Given this list of marker genes CAPNS1, MPV17, DNAJC21, GTF2IRD1, RTN2, SVIL, GATB, TAMM41, SETX, NCF1, KRT5, UROS, G6PD, CIITA, STAT2, FOXP3, COL4A3, KIT, FKTN, WDR73, NPHS2, HEXB, TSHB, FOXI1, SLC40A1, SLC22A5, LAMA1, RRM2B, PIGA, SLC25A4, GYG1, CPOX, SERPINA6, NOS1 (NCBI Gene Id 4842, nitric oxide synthase 1), ARPC5, LIN28B, FRG1, PROP1, ALG12, MYOT, PHKG2, BSCL2, PDK3, AGPAT2, IRF5, PHKB, ACSL5, TNPO3, PLA2G6, MPI, SIL1, KY, ALG2, B4GALT1, PLVAP, LPL, IYD, ATP6V1A, LMNA, SGCD, DGKE, LDHA, DOK7, ISCU, COA7, HADH, TTN (NCBI Gene Id 7847), IFT56, STIM1, AP1B1, SLC7A7, PAX8, ARHGAP24, ADSS1, DPAGT1, MYMK (NCBI Gene Id 389827), RRM1, SKIC3, MGME1, CEL, GPR35, PIGN, PKLR, CCDC115, CNOT1, NUP107, MB, SYNJ1, TNNT2, TRAF3, TWNK, NLRP1, THPO, LYST, HMOX1, COL12A1, DHCR7, PYROXD1 (NCBI Gene Id 79912), MAP2K1, QRSL1, POPDC3, PITRM1 (NCBI Gene Id 22910), BCS1L, GNPTG, SMCHD1, TBCD, GNPTAB, ASAH1, CTNNB1, ZNFX1, USB1, HNRNPA2B1, ABHD5, ACTN4, ALG14, MYH14, C1QBP, IL6ST (interleukin 6 cytokine family signal transducer), FN1, HADHA, WDR4, STX1A, ABCG8, TMEM199, MEFV, POLG2, BAG5, GGPS1, RNF31, TBCK, DMD, BICD2, SLC30A9, DSG2, TMEM270, COL25A1, CASR (calcium sensing receptor), INS (NCBI Gene Id 3630), NGLY1, SLC34A1, ADRA2A, QRICH1, EMP2, FOS, CLIP2, FAS, HLA-DPB1, EPG5, MYPN, KLKB1, NUP37, HMGCR (3-hydroxy-3-methylglutaryl-CoA reductase), PIEZO1, CIDEC, COX16, PLCG1, SLC34A3, TRPV4, PTPN22, DPM1, ACAD9 (NCBI Gene Id 96656), POMT2 (NCBI Gene Id 29954), TMPRSS15, DHX16, HNF4A (hepatocyte nuclear factor 4 alpha), NRAS, ANLN, PLIN4, TANGO2, CPA1, HLA-DPA1 (major histocompatibility complex, class II, DP alpha 1), COL9A3, LYN, NPHS1 (NPHS1 adhesion molecule, nephrin), TOP3A, LDB3 (LIM domain binding 3), STEAP3, MIEF2, TMPRSS6, KBTBD13, LMOD3, DNA2, PMM2, STXBP2, MTMR14, STAB1, TK2, PGM1, SLC30A10, TCAP, NFS1, COL4A1, POLRMT, SLC16A1, ELF4, HHAT, IL6R, PHKA2, NSUN2, CD2AP, SLC4A4, MT-TL2, TIMM22 (NCBI Gene Id 95988), RXYLT1, RFX5, ALG6, TICAM1, DEF6, STX11, POGLUT1, UCP2, KNG1, TFAM, PLEKHG5, EFL1, TTR, B3GALNT2 (NCBI Gene Id 148789), KCNE3, MET, CFTR, TOR1AIP1, CD244, TMTC3, INSR, IL1RN, TF, PLCE1, UBR1, SCYL2, MCM10, KLF11, CPT1A, CSF2RA, DNMT3B, APOA1, KIF12, LARGE1, DUX4, SLC12A6, KIF23, CARD10, AMACR, SGPL1, TNFRSF1A, MEGF10, CRB2, COL7A1, ATP7A, AP5Z1, TG, ITGA7, NOTCH2NLC, PRF1, SLC25A13, COQ8B, BAZ1B, INPP5K, KCNN4, DMGDH (NCBI Gene Id 29958), SLC25A38, C1GALT1C1, CP, MT-TN, SLC25A42, ALDOA, NKX2-5, PAX4, UQCRFS1, CLDN16, DUOX2, GATA1, CACNA1S (calcium voltage-gated channel subunit alpha1 S), PRSS1, TFG, CORIN, SUOX, MICU1, C2orf69 (chromosome 2 open reading frame 69), TSFM, NUP85 (NCBI Gene Id 83705), OTULIN, DGAT1, PDX1, SCARB2, KCNJ10, HNF1A, FKBP14, RFXANK, STK11, CRPPA, NOS1AP, RFXAP, COL6A1, SPTAN1, GLRX5, MMEL1, PYGM, CAV1, TDP1, PEX6, P4HA2, KARS1, TCF4, SAR1B, MST1, NPR2, FARSB, SLC25A20, ELN, SCN4A, CCND1, CNBP, GOSR2, ANO5, FOCAD, UNC93B1, PAX2 (paired box 2), CRYAB, AHCY, FKBP6, UBAC2, HAVCR2, GBE1, THRB, SYNE1, KLRC4, EMD, GCK, MVK, SLC25A36, SPIB, CCDC78, NUP133, RBP4, PSTPIP1, LHX3, MLIP, MFN2, SGCB, GMPPB, FOXE1, SLC39A14, ERGIC1, FTL, NLRP12, COG6, RAG1, HBB, SLC35A2, AP1S1, STAT4, SQOR, XK, PRPS1, MYH7, POU1F1, ANXA11, HLA-DQB1, DNM2, DNAJB4 (NCBI Gene Id 11080), MYO5B, PRTN3, ATP5F1D, AMPD1, BVES, SPEG, COL6A2, PIK3R5, TKFC, HLA-DRB1, LACC1, AASS, AMPD3, MAGI2, KLHL9, ALG8, DNAJC30, AR, NEFH, CHCHD10, MICOS13, DUX4L1, POU2AF1 (POU class 2 homeobox associating factor 1), MYZAP, EIF2AK3, TRPC6, ZBTB20, RHAG, LRP12, FLNC (NCBI Gene Id 2318), DCXR, LMO1, COQ2, SCO2, MTTP, LAMP2, TRIM32, NFKBIL1, PNPLA2, IL12A, BMP6, SLC19A1, C4A, SPINK1, ITGB2, SLC31A1, TRHR, PNKP (polynucleotide kinase 3'-phosphatase), FLI1, POMP, TNFSF15, LHX4, COG2, FARSA, HJV, VCP, TMEM38B, IGFALS, ACADM, KCNA1, ISCA1, IFNG, MT-TE, LPIN1, TLR4 (toll like receptor 4), SLC2A1, DYSF, SLC5A5, IL12A-AS1, GBA1, ARPC1B, HNRNPA1, SUCLA2, SYNE2, BRAF (B-Raf proto-oncogene, serine/threonine kinase), TRAPPC11, MLX, KRT14, PKD2, CD55, TBC1D8B, CHKB, TRPV6, RNASEH1, CNTN1, PABPN1, ATP6V0A2, C1QB, AFP, IL10, NEFL, CFL2, SLC34A2, PTPRO, ORAI1, YME1L1, ERAP1, TRIP4, GFPT1, NCF4, DPYS, KLF1, TPM3, BAG3, CAVIN1, GABRA3, CCT5, PUS1, GTF2IRD2, PRSS2, AIFM1, BLK, SGCG, NKX2-1, NR1H4, RBCK1, CTLA4, LIPE, VRK1, ITK, COG7, IL12RB1, BIN1, PKHD1, NPPA, RASA1, FTH1, ATP6V1E1, KCNJ18 (NCBI Gene Id 100134444), OBSCN, UNC13D, ALB, PRKCD, CAPN3, IL6, CCBE1, HLA-DQA1, OTUD5, MYL1, ITGA3, ADK, RNF168, FHL1, IARS1, VMA21, PTPN6, APOC2, IFIH1, VPS13A, PIGY, TBL2, SERPINE1, AGL, PET100, MPZ, NUP205, IL37, DCLRE1C, LTBP4, IL12B, SNUPN, SDHD, CASK, TPO, PFKM, PGAM2, VPS33A, RFC2, PLG, NEB (NCBI Gene Id 4755), ACTN2, LYRM7, RYR1, HINT1 (histidine triad nucleotide binding protein 1), HAMP, GAPVD1, GATC, NLRP3, FAH, ALG1, NEUROD1, PIEZO2, LARS2, CCR1 (NCBI Gene Id 1230), SLC4A1, COX20, STING1, ANKFY1, HACE1, MSTO1, BCL10, SLC33A1, RNU7-1, FAM111B, PIK3CG, SUGCT, ATP7B, LIMK1, PLXNA1, KLHL41, NUP93, PHKA1, RHD, PTEN, POLG, MYCN, HADHB, ATM, NARS2, HSPG2, PPARG, HLA-B, IL23R, PSMB8, WT1, DGUOK, EARS2, XIAP, DPM2, SLC26A4 (NCBI Gene Id 5172), ITGB4, SPTBN4, BUD23, ERCC4, UBA1, PHKG1, CAV3, TMEM165 (transmembrane protein 165), APOL1, VAPB, DNAJB6, VAC14, HNRNPDL, MT-CO3 (mitochondrially encoded cytochrome c oxidase III), NAB2, IL36RN, ABCC8, ENO3, PHOX2B, TRMU, MYF6, EIF4H, ALK (NCBI Gene Id 238), COPA, ACTA1, NUP160, ABCA1, FILIP1, CRLF1, PANK2, HFE, MYL2, FDX2, GFER, COL6A3, MYO1E, B2M, COQ4, DSG1, APTX, C19orf12 (NCBI Gene Id 83636), RHCE, TNNT1, CTRC, DAAM2, OCRL, ALG9, CBLIF, KCNJ11, HACD1, OSGEP, HESX1, RAG2, PSMB9, BMP2, SQSTM1, POMGNT2, COG8, IFNGR1, DPM3, SLCO2A1, GAA, LAMA2, APPL1, FGFR3, ADA2, SH2D1A, ARHGDIA, PRUNE1, TRAPPC2L, METTL27, MPDU1, NLRC4, GNE, TSHR, TMEM43, SMAD4, RILPL1, DUOXA2, SGCA, ACADVL, DES, CCN6, PLEC (plectin), CASQ1, GLIS3, CPT2, DAG1, CSF2RB, VPS37D, TFR2 (transferrin receptor 2), TBK1 (NCBI Gene Id 29110), MATR3, TIA1, MIF, SERPINA1, SYK, TPM2, FKRP, TLR3, B4GAT1, PAPPA2 (pappalysin 2), SBDS, INF2, JAG2, AGXT, CA2, IRF8, POMT1, AP1S3, POMGNT1, SEMA4D, POMK, BMPR1A, GOLGA2, SLC22A4, MKS1, MT-TL1, MAD2L2, LAMB2, MT-CO1, GIPC1, PDSS2, LIMS2, GTF2I, STAT6, FLAD1, here is a description of the gene set: Abnormal circulating protein concentration studied in species Homo sapiens Human Gene Set: HP_ABNORMAL_CIRCULATING_PROTEIN_CONCENTRATION An abnormal level of a circulating protein in the blood.